Given this list of marker genes CAPNS2, APP, LMNA, CAST, FOXO3, FASLG, BCL2L11, PRDX1, CDK5, CDC25A, CAPN2, CAPN1, LMNB1, CAPNS1, YWHAE, GOLGA2, PRDX2, CDK5R1 (NCBI Gene Id 8851), CDC25C (cell division cycle 25C), CDC25B, SOD2, JUN, here is a description of the gene set: part of: Defective Intrinsic Pathway for Apoptosis Reactome Pathway: Neurodegenerative Diseases studied in species Homo sapiens Neurodegenerative diseases manifest as the progressive dysfunction and loss of neurons, which is frequently accompanied by formation of misfolded protein deposits in the brain. Classification of neurodegenerative diseases is based on clinical symptoms, which depend on the anatomical region affected by neuronal dysfunction, the identity of misfolded proteins and cellular and subcellular pathology.<br>In Alzheimer’s disease (AD), beta-amyloid protein (APP) deposits form in the extracellular space, where they can make plaques, while abnormally phosphorylated tau protein (MAPT) accumulates in neuronal cells.<br>Beside AD, neuronal and/or glial inclusions of hyperphosphorylated tau are also found in Pick disease (PiD), neurofibrillary tangle-dementia (NFT), primary age-related tauopathy (PART), progressive supranuclear palsy (PSP), corticobasal degeneration (CBD), argyrophilic grain disease (AGD) and globular glial tauopathies (GGT).<br>In prion disease, such as Creutzfeldt-Jakob disease, deposits of PrP protein are formed mostly in the extracellular and presynaptic space. PrP deposits in neuronal cell bodies are mainly confined to endosomes and lysosomes, which is attributed to neuronal uptake of pathological proteins and intercellular prion spreading.<br>In Parkinson disease (PD) and dementia with Lewy bodies (DLB), deposits of alpha-synuclein (SNCA) are formed in the cytoplasm of neuronal cell bodies and neurites. In multiple system atrophy (MSA), deposits of alpha-synuclein form in the cytoplasm of glial cells (Papp-Lantos bodies).<br>Amyotrophic lateral sclerosis (ALS) and frontotemporal lobar degeneration (FTLD) are characterized by ubiquitin-positive cytoplasmic inclusions of TAR DNA-binding protein 43 (TARDBP, commonly known as TDP-43), a protein that normally localizes to the nucleus. Pathological TDP-43 inclusions have been associated with the TDP-43 gene mutations, as well as mutations in several other genes, including C9orf72, GRN, VCP, SQSTM1, DCTN1 and OPTN. TDP-43 inclusions have also been reported in AD, DLB, hippocampal sclerosis (HS) and chronic traumatic encephalopathy.<br>FUS protein-positive inclusion bodies are found in familial ALS, caused by mutations in the FUS gene, as well as in a small subgroup of FTLD-related diseases. FUS-positive inclusions may be accompanied by FET protein-positive inclusions.<br>For a detailed review of molecular pathology of neurodegenerative diseases, please refer to Kovacs 2016.<br>Within this broad domain, the process by which APP-triggered deregulation of CDK5 (cyclin-dependent kinase 5) triggers multiple neurodegenerative pathways associated with Alzheimer's disease has been annotated.